The following is a description of a gene set: Human Gene Set: HP_SYNOSTOSIS_OF_METACARPALS_METATARSALS Synostosis of metacarpals/metatarsals species: Homo sapiens, and this is the list of marker genes: ZIC1, NOG, NONO, BHLHA9, POR, SMOC1, HOXD13, FGFR3, LRP4, PQBP1, GDF5, EIF4A3, MAP3K20, TWIST1 (twist family bHLH transcription factor 1), SLC26A2, TCF12, FGF9, FBLN1, FGF16, SALL1